The following is a description of a gene set: Genes up-regulated in peripheral blood mononuclear cell 3d vs 0d in adults (18-50) after exposure to FluMist, time point 3D. Comment: Supplementary Table 1b: All the differentially expressed genes identified in PBMCs of TIV vaccinees. Human Gene Set: NAKAYA_PBMC_FLUMIST_AGE_18_50YO_3DY_UP Here we have used a systems biology approach to study innate and adaptive responses to vaccination against influenza in humans during three consecutive influenza seasons. We studied healthy adults vaccinated with trivalent inactivated influenza vaccine (TIV) or live attenuated influenza vaccine (LAIV). TIV induced higher antibody titers and more plasmablasts than LAIV did. In subjects vaccinated with TIV, early molecular signatures correlated with and could be used to accurately predict later antibody titers in two independent trials. Notably, expression of the kinase CaMKIV at day 3 was inversely correlated with later antibody titers. Vaccination of CaMKIV-deficient mice with TIV induced enhanced antigen-specific antibody titers, which demonstrated an unappreciated role for CaMKIV in the regulation of antibody responses. Thus, systems approaches can be used to predict immunogenicity and provide new mechanistic insights about vaccines. from publication Nakaya HI, Wrammert J, Lee EK, Racioppi L, Marie-Kunze S, Haining WN, Means AR, Kasturi SP, Khan N, Li GM, McCausland M, Kanchan V, Kokko KE, Li S, Elbein R, Mehta AK, Aderem A, Subbarao K, Ahmed R, Pulendran B (PMID 21743478) species: Homo sapiens, and this is the list of marker genes: ECHDC1, CPNE8, TMT1A, ECHS1, DTX3L (NCBI Gene Id 151636), COA4, TMEM230, OGFOD1, CREBL2 (NCBI Gene Id 1389), AMN1, CBR1, SYTL3, DERA, RUBCN, IDH3A, PPHLN1, PANK2, HOXA7, ZNF106, IL10RB, CITED2, CASP1, SART3, TM9SF1, MFSD14B, VRK2, CHMP4A, CLCN3, CLEC4A, AP1S2 (adaptor related protein complex 1 subunit sigma 2), TLR7, MRPL20, CROCC, PCED1B, YWHAB, CRTAP, B3GALT6, CDK13, HFE, SERF2, CTNND1, TMEM80, RSL1D1, NUB1, PRPF6, HAUS7, TRMT112, OXLD1, DCTD, ETFA, TRIO, TCF4, CROCCP2, AIF1, PARP14, AKIP1, AGPAT3, EHBP1L1, RBM8A, SAMD9L, OCIAD1, ITPRIPL2 (ITPRIP like 2), ABHD18, NSL1 (NCBI Gene Id 96380), VAV1, SHTN1, DDOST, SYK, CD14, EXOSC5 (NCBI Gene Id 56915), DPP8, POLK, TRIP11, KLHL6, SLC7A7, PIGP, MRPS11, RXRA, C11orf68, RNF20, ILK, IKZF1, AOAH, IFT80 (intraflagellar transport 80), HNRNPA0, CHST15, PLPBP, LMO2, BZW2, HLA-DRB1, LBHD1, EPB41L3, ARMH3 (NCBI Gene Id 79591), NDUFS2, CHKB, XRCC5, TSPAN31, SUMF1, CD93, SLC31A1, PDXK, RPUSD3 (RNA pseudouridine synthase D3), PPA2, RAB8A, SPTSSA, NUP214, PECAM1, CLTA, TBXAS1, RRP12, LAIR1, PDCD6, CUEDC2, SYNCRIP, CEBPA, RTCB, HIPK2, KIAA0930, NDUFAF3, ORAI3, CSK, KRTAP2-4, ABCF2, CST3, TICAM2, PARP12, TCF7L2 (NCBI Gene Id 6934), CTNNA1, SAT2, MYCBP, DNASE2, BLVRA, DYNLL1, AGPS, FKBP5, CYC1, DDX18, SMARCA4, RAB4B, MICOS10, CMTM7, SLC27A3, SIDT2, PRAM1, AURKAIP1, MEGF9, PHYKPL, ARPC1B, LTA4H (leukotriene A4 hydrolase), TMEM126B, SNX2, UBE2I, CTDSP2, MFSD1 (major facilitator superfamily domain containing 1), GTF2H2C_2, PYCARD, SAMHD1 (SAM and HD domain containing deoxynucleoside triphosphate triphosphohydrolase 1), CTSB, RNF5, PCK2, PDHB, JAK2, DCTN2 (dynactin subunit 2), ADAP2, EAF2, GNS, IKZF3, PPP1R11, ARRB1, SDR39U1, IDH3G, DMAC1, REEP5, RAP1GDS1, TRIM5, AAMP, RASSF4, PPT1, GOLIM4 (NCBI Gene Id 27333), MRM2, COA3, PUDP, MYD88, VPS41, SEC22B, STAT1, PSMB9, TLR8, ATP6V0D1, SHMT2, SLX1A, TRIQK, NDUFB10, CLN5, NAAA, CHMP5, SCAMP2, SMIM14, TNFSF13B, NAIP, PCMTD1, SMURF2, ARSD, PPID, SLC24A4, HPSE, CD36, NCOA2, GPAA1, PCMT1, HCG18, GIT2, NUDT5, PLOD3, XAF1, AGTRAP, FGD4, PSME3IP1, NOTCH2, USP34, MAT2B, PRR5L, HK1, TAF4, ARPC5, NADK, MKKS, PPP1R7 (protein phosphatase 1 regulatory subunit 7), SP110, N4BP2L1, NAGA, NOLC1, KLHL36, CARD16, TBC1D8, TPI1, EIF2AK1, BTK, TRIM22, NECAP2, CSTB, PEA15, TNFSF13, DCTPP1 (dCTP pyrophosphatase 1), HLA-DMB, MAPK1 (NCBI Gene Id 5594), MS4A6A, CAMKK2, NDUFB5, MESD, LARP1, FKBP15, ENO1, GRK3, ZFAND5, RRP7A, USP19, MYOF, REEP4, OAS2, ATP6V1C1, GTF2H2C, CFP, FCN1, ASRGL1, RUFY3 (RUN and FYVE domain containing 3), SNX6, IFI35, LDAH, TNS3, GPBAR1, PLBD1, IFI30, RPRD2, CNDP2, PUSL1, COX5A, EXOSC1, DDX60, ADAM10, TNFSF10, YY1AP1, RGS19, SLX1B, YWHAE, HM13, HMGN4, BTF3L4, DPAGT1, MARCHF1, DMXL1, EMILIN2, TM9SF4, ZC3H4, SELENOH, RNF135, ALDH2 (aldehyde dehydrogenase 2 family member), SBNO1, SLC24A1 (NCBI Gene Id 9187), XIAP, SEC23IP, TRIM34, TREX1, SERBP1, AIMP2, RB1, ALDH9A1, RNH1, MGST3, PLSCR1, DYNC1I2, CBL, S100Z, CYP4V2, EFTUD2, SLC22A18, GRSF1, LEPROT, ZNHIT1, AK2, TMED9, TKT, MAT2A, PRELID1, CYFIP1, TMPO, CORO1C, IL17RA, SQOR (sulfide quinone oxidoreductase), MPEG1, CIAO2A, DRG1, IGHG1, HEBP1, APPL1, PRDX4, TCF3, MX2, CD86, CARD9, MRPL51, LARP4B, BCKDHA, IRF5 (interferon regulatory factor 5), FGR, LIMS1, PARP1, BANF1, MARCO, HTATIP2 (NCBI Gene Id 10553), TRIM69, PTBP1 (NCBI Gene Id 63477), PREPL, HYPK (NCBI Gene Id 51500), TSPAN4, FBP1, TMX1, CD84, PRPF19, SMIM7, RDH11, TMBIM4, HHEX, SSB, MEF2C, PMVK, PIEZO1, ATP5MF, TPST2, SNX1, PIK3AP1, DNLZ, COMT, KCNE3, IRF7, PGLS, CYBC1, SPTLC1 (serine palmitoyltransferase long chain base subunit 1), SSR1, STAT2 (NCBI Gene Id 6773), OSCAR, GDI2, SLC12A7, RAB27A, CNP, SULT1A1, DAPK1, SNX17, TNRC6B, GATAD1, NIPAL3, FUCA1, PLXNB2, PIK3C3, MAP4, AKR1A1, PSMB2 (NCBI Gene Id 5690), DDX60L, MRPS16, ASXL2, INTS7, ADA2, PGD, HVCN1, FCGR1BP, CTSS, AP2S1, GRN, TRAPPC3, SLC2A6, AP3D1, ORMDL2, SUSD1, IDH2, AAK1, AP2A2, CCDC50, QKI, TANGO2, NIF3L1, CYB561A3, TMEM205, RAB10, ARHGAP17, RTN1, ITPR2, GSTP1, SNTB2, CSNK2A1, TOR1B, CLPTM1, NAGK, ESRP2, RAB40C, GALNT2, MED16, KIAA0513, FGL2, PSMB10, UNC50, SH2D3C, TINF2, TMED7-TICAM2, SRD5A3, METTL8, FASTK, DPH3, STX7, RAB3GAP1, UCP2, CIITA (class II major histocompatibility complex transactivator), SMCO4, TCEANC2, AFG3L2, CYBB, TRIM14, MX1, SYNE3, ALDH3A2, IGHM, COX20, HK3, CPVL, FCER1G, GEMIN7, LARS1, GAS7, PDIA6, DPYD, CTSC, GTF2H2, LILRB1, EBNA1BP2, SERPINB1, TNFSF12-TNFSF13, LSM6, UEVLD, GSTO1, CTBP2, MANF, SNX27, MRPL24, COMMD8, OCA2, APOL3, GLYR1, MAP2K1 (mitogen-activated protein kinase kinase 1), CD302, GTF3C2, SDHC, PTGER2, GATD3, KCTD12, SUCLG1, PDLIM5, TOR1A, MS4A4A, RMDN1, NUDT22, IFI16, PAICS, ZNF143, HCK, CHTF8, OAS3, BST2, SLC25A24, GLRX (glutaredoxin), LILRA1, PGM2, SCARB2, MRPL16, SPTLC2, ANTKMT, MLKL, EXOC4, ATP10D, NDUFB3 (NADH:ubiquinone oxidoreductase subunit B3), FAM110A, TMEM63A, RBBP4, WSB1, SRGAP2C, GASK1B, PLAC8, CAST, ATP6V1A, OAS1, UNC93B1, RHBDD1 (rhomboid domain containing 1), RNFT1, GCNT2, RTL8C, BLNK, TMEM209, PHPT1, TRIM6-TRIM34, MRPS18C, CDIP1, ERCC1, UBE2L3, KYNU, ATIC, ALDH1A1, TIMM8B, SCPEP1, ATP5PD, ASH2L, LY6H, ICE2, LSM10 (LSM10, U7 small nuclear RNA associated), CES2, NDUFS7, APLP2, DCAF7, STX4, FGD2, MLX, ATP6V1B2, FAM204A, TMEM19, ENY2